The following is a description of a gene set: The lung adenocarcinoma TSP (tumor sequencing project) genes mutations in which show positive correlation with the higher overall mutation rate. species: Homo sapiens Determining the genetic basis of cancer requires comprehensive analyses of large collections of histopathologically well-classified primary tumours. Here we report the results of a collaborative study to discover somatic mutations in 188 human lung adenocarcinomas. DNA sequencing of genes with known or potential relationships to cancer revealed more than 1,000 somatic mutations across the samples. Our analysis identified genes that are mutated at significantly high frequencies and thus are probably involved in carcinogenesis. The frequently mutated genes include tyrosine kinases, among them the EGFR homologue ERBB4; multiple ephrin receptor genes, notably EPHA3; vascular endothelial growth factor receptor KDR; and NTRK genes. These data provide evidence of somatic mutations in primary lung adenocarcinoma for several tumour suppressor genes involved in other cancers--including NF1, APC, RB1 and ATM--and for sequence changes in PTPRD as well as the frequently deleted gene LRP1B. The observed mutational profiles correlate with clinical features, smoking status and DNA repair defects. These results are reinforced by data integration including single nucleotide polymorphism array and gene expression array. Our findings shed further light on several important signalling pathways involved in lung adenocarcinoma, and suggest new molecular targets for treatment. Human Gene Set: DING_LUNG_CANCER_BY_MUTATION_RATE from publication Ding L, Getz G, Wheeler DA, Mardis ER, McLellan MD, Cibulskis K, Sougnez C, Greulich H, Muzny DM, Morgan MB, Fulton L, Fulton RS, Zhang Q, Wendl MC, Lawrence MS, Larson DE, Chen K, Dooling DJ, Sabo A, Hawes AC, Shen H, Jhangiani SN, Lewis LR, Hall O, Zhu Y, Mathew T, Ren Y, Yao J, Scherer SE, Clerc K, Metcalf GA, Ng B, Milosavljevic A, Gonzalez-Garay ML, Osborne JR, Meyer R, Shi X, Tang Y, Koboldt DC, Lin L, Abbott R, Miner TL, Pohl C, Fewell G, Haipek C, Schmidt H, Dunford-Shore BH, Kraja A, Crosby SD, Sawyer CS, Vickery T, Sander S, Robinson J, Winckler W, Baldwin J, Chirieac LR, Dutt A, Fennell T, Hanna M, Johnson BE, Onofrio RC, Thomas RK, Tonon G, Weir BA, Zhao X, Ziaugra L, Zody MC, Giordano T, Orringer MB, Roth JA, Spitz MR, Wistuba II, Ozenberger B, Good PJ, Chang AC, Beer DG, Watson MA, Ladanyi M, Broderick S, Yoshizawa A, Travis WD, Pao W, Province MA, Weinstock GM, Varmus HE, Gabriel SB, Lander ES, Gibbs RA, Meyerson M, Wilson RK (PMID 18948947), and this is the list of marker genes: ACVRL1, PRKDC, PTPRD (protein tyrosine phosphatase receptor type D), PIK3C2G, PTPRG, INSRR, LMTK3, FGFR4, TYK2, LRP1B, NTRK2, TP53, SMG1, ROBO2, PDGFRA, IRS1, MYB, VAV1, DDR1, MAST4